The following is a description of a gene set: The adhesion of one platelet to one or more other platelets via adhesion molecules. species: Homo sapiens Human Gene Set: GOBP_PLATELET_AGGREGATION, and this is the list of marker genes: EMILIN2, FIBP, FGB, COMP, STXBP3 (syntaxin binding protein 3), HTR2A, CTSG, FGG, ACTB, MMRN1, TYRO3, BLOC1S4, PRKCQ, UBASH3B, SLC7A11, GATA1, MYH9, TLN1, CSRP1, TUBB1, GP6, FGA, SYK, CLIC1, VCL (NCBI Gene Id 7414), TSPAN32 (tetraspanin 32), TMX1, PRKCD, IL6ST, PDPN, STXBP1, CELA2A, FLNA, PRKG1, MYL12A (NCBI Gene Id 10627), FERMT3, PDIA3, VPS33B, HBB, CEACAM1, PEAR1, IL6R, SERPINE2, ADAMTS18, F2RL3 (F2R like thrombin or trypsin receptor 3), ACTN1, SLC6A4, JAK2, ITGB3, PLEK, F11R, ENTPD1, C1QTNF1, PIK3CG (phosphatidylinositol-4,5-bisphosphate 3-kinase catalytic subunit gamma), P2RY12, LYN, PRKCA, SH2B3, MFSD2B, PDIA2, EMILIN1, MYL9, IL6 (interleukin 6), PIK3CB, RAP2B, GNAS, PTPN6, PDGFRA, ADGRG1, PPIA, ACTG1, ILK, TSPAN9, HSPB1 (NCBI Gene Id 3315), CD9, WNT3A, METAP1, ALOX12